Given this list of marker genes Fgf23, Fgfr4, Slc17a8 (NCBI Gene Id 216227), Alpl, Rnls, Abcc6, Hoxa3, Slc17a7, Slc17a6, Umod, Slc34a2, Slc34a3 (NCBI Gene Id 99048), Slc34a1, Sfrp4 (secreted frizzled-related protein 4), Nherf1, Enpp3, Tmem174, Enpp1, Spp1, Ank, Pthlh, Pth, Gcm2, Xpr1, here is a description of the gene set: Mouse Gene Set: GOBP_PHOSPHATE_ION_HOMEOSTASIS Any process involved in the maintenance of an internal steady state of phosphate ions within an organism or cell. species: Mus musculus